Given this list of marker genes TPM3, SELENON, GFM2, HACD1, TP63, FOXP2 (forkhead box P2), GPT2, CREBBP, MT-TE, EDEM3, TPM2, BRAF, UNC80, CTCF, TRMU, SNRPN, IDH1, MYL2, GRM7, PSAP, PIGT, SATB2, ITGA7, NALCN, GALC, TFG, PUF60, CLTCL1, KANSL1 (KAT8 regulatory NSL complex subunit 1), PDE10A, COX8A, COL2A1, MAP3K20, HNRNPK, ACTA1, DYRK1A, EP300, here is a description of the gene set: Feeding problem necessitating nasogastric tube feeding. Nasogastric tube feeding in infancy Human Gene Set: HP_NASOGASTRIC_TUBE_FEEDING_IN_INFANCY species: Homo sapiens